The following is a description of a gene set: Human Gene Set: GSE41176_WT_VS_TAK1_KO_ANTI_IGM_STIM_BCELL_6H_UP studied in species Homo sapiens Genes up-regulated in B lymphocytes treated by anti IgM for 6h: wildtype versus MAP3K7 knockout. The activation signaling of transcription factor nuclear factor-kB (NF-kB) plays central role for immune system. One of key kinase mediating this pathway is TAK1 in adaptive and innate immunity. However, role of TAK1 in B cell receptor signaling is still unclear. To know effects of TAK1-deletion on the gene expression induced by anti-IgM, we performed the time course analysis in comparison of wild type with TAK1-deleted splenic B cells. from publication Shinohara H, Behar M, Inoue K, Hiroshima M, Yasuda T, Nagashima T, Kimura S, Sanjo H, Maeda S, Yumoto N, Ki S, Akira S, Sako Y, Hoffmann A, Kurosaki T, Okada-Hatakeyama M (PMID 24833394), and this is the list of marker genes: AFMID, ZNF410, MOSMO, SRRD, ZNF800, GPR22, ZBTB37, ATG3, ASGR2, TTC1, VAMP7, EWSR1, HNF1A, KDM1B, ZNF347, FBLN7, ZNF474 (zinc finger protein 474), CXCL3, GSK3B, SUMF2, ZNF600, KIAA0825, INTS12, GPR19, UBQLN3, SLC30A8, MOB4, EFCAB7, MARCHF7, SOX15, ZNF335, ETV3, SLC25A16, FAM204A, AFF4, BTG2, CCDC150 (NCBI Gene Id 91531), KIN, HAVCR1, MBIP, PDE4B, SNX21, ACBD5, ADRB2, INSYN2B, POF1B, ZNF597, IRX3, JAM2, MAP3K8, VSNL1, BECN1, AVL9, OSM, ADAMTS12, STARD3NL, EBF3, IL10, MT2A, PRXL2C, C1orf141, KAZN, PRSS23, ARID5A, ESCO1, THBD, KRT18, NAP1L2, PPP4C, TMEM132C, PRICKLE3, CD69, DNAAF11, KDM6B, NUP42, HLA-DOB, NSUN3, TMPRSS11D, HNRNPR, CSRNP1, RASL11A, AKAP4, SNORD89, SMIM23, DYNLRB2, CCL4, MET, LCORL, PTGFRN, CELF1, SEC22A, CZIB, JOSD2, POGZ, CUBN, SPINDOC, KBTBD3, FUT2, CTBS, ZBTB44, RAP2B, THUMPD3, RND3, GADD45G, AHR, FLI1, FSCN2, CAVIN2, FOS, NINL, MYOM1, IRF1, ZFP36, IGLON5, SLC25A20, FLRT3, TATDN3, DUSP1, CD320, SCOC, KRT20, KLHDC2, AIM2, PTGS2, FBXO8, NCKAP5, TTC19, IGFBP2, MEIG1, UTP23, SMN1, EBF4, IER3, TREM2, AIMP2, NLRP3, SPATA1, PIGN, ADA, THNSL2, CFLAR, LRRC4B, DNAJB6 (DnaJ heat shock protein family (Hsp40) member B6), PROSER1, FILIP1L, IL1B, BCAS2, SEPTIN6 (septin 6), NFIL3, KLHL9, GTPBP3, MT1E, IER2, ADAMTS1, DUSP2, GNA11, TNFSF9, PNRC1, OTX2, TUBB2A, WDR20, BTF3L4, PEX3, GRM5, ORM2, SEC24A, ING3, ALDH1B1, SMARCA2, NADSYN1, GRIN2C, ALOX15, PDILT, SBNO2, LCOR, USP33, ARID4B, PLSCR1 (phospholipid scramblase 1), BPNT1, SS18, ABTB1, COQ10B, PCDHB15, MALT1, MEAF6, MTFR1 (NCBI Gene Id 9650), CXCL2, ECHS1, CIRBP, KBTBD7, CHM, HIF1AN, SOCS3 (suppressor of cytokine signaling 3), DR1, HNRNPH2, RBM7, NME5, IL20RB, CCNC, UBE2D1